Given this list of marker genes GRB10, MT-ND3 (NCBI Gene Id 4537), EIF4G1, MT-ND4, NSUN2, NIPBL, FOXP2, VPS35, HDAC8 (histone deacetylase 8, NCBI Gene Id 7492), ITPA, SNCA, TRMT10A (tRNA methyltransferase 10A), LRRK2, MT-TK, SYT2, BRD4, IGF1R, HSPG2, CWF19L1, MT-TV, LIG4 (DNA ligase 4), MT-ND2, ADAMTSL2, MT-ATP6, PPP1R15B, MTX2, CFL2, P4HB, TTN, RIN2, GBA1, MED12, MT-ND1, ARID1B, STAT5B, MT-TL1, WRN, SUZ12, FBXO7, NBAS, SEC24D, MORC2, RBBP8, FMR1, TRPS1, SEMA5A, FAM111A, BLM, RAD21, SRPX2, AR, SELENON, LMNA, SMC1A, ERCC4, MT-ND6, EZH2, POLD1, MT-TW, SERPINH1, XRCC4, SMARCAL1, GHR, CTNND2, SMC3, POC1A, MAPT, MT-ND5, MDM2, ORC4, SRCAP, NSD1, CHRNB1, ZMPSTE24, MFN2, DNAJC13, BSCL2, TRIM37, TAF6, GRIN2A, MYH7, GIGYF2, PCNT, here is a description of the gene set: Abnormal prosody Human Gene Set: HP_ABNORMAL_PROSODY species: Homo sapiens Prosody refers to the patterns of rhythm, stress, and intonation in spoken language. Abnormal prosody refers to abnormalities in the patterns of rhythm, stress, or intonation of speech or vocalization that can be heard by the observer. In general, this refers to overt and clear deviations in patterns from culturally accepted norms but many also include differences noted in comparison to the usual patterns of the individual (a quiet person suddenly becomes loud or vice versa).